The following is a description of a gene set: Neighborhood of CDH5 Neighborhood of CDH5 cadherin 5, type 2, VE-cadherin (vascular epithelium) in the GCM expression compendium species: Homo sapiens Human Gene Set: GCM_CDH5, and this is the list of marker genes: PTPRU, ITSN1, KRT32, SLC10A1, AGER, LYST, ADCYAP1, CHIC1, NDUFA1, COL14A1, IFNA21, ERV3-1, TAF1, APOC3, CD8B, CSN3, POLR1HASP, MVK, CALCRL, ZNF8, SLC30A3, CCR9, GABRQ, SLC18A1, AVPR1B, MPP2, PSG7, AANAT, CTLA4, FANCC, SUPT4H1, HMGA2, FEV, CDH5, GH2, SLC17A2